The following is a description of a gene set: Human Gene Set: SCHAEFFER_SOX9_TARGETS_IN_PROSTATE_DEVELOPMENT_UP Predicted targets of SOX9 that are up-regulated during early prostate development. from publication Schaeffer EM, Marchionni L, Huang Z, Simons B, Blackman A, Yu W, Parmigiani G, Berman DM (PMID 18794802) studied in species Mus musculus Cancer cells differentiate along specific lineages that largely determine their clinical and biologic behavior. Distinct cancer phenotypes from different cells and organs likely result from unique gene expression repertoires established in the embryo and maintained after malignant transformation. We used comprehensive gene expression analysis to examine this concept in the prostate, an organ with a tractable developmental program and a high propensity for cancer. We focused on gene expression in the murine prostate rudiment at three time points during the first 48 h of exposure to androgen, which initiates proliferation and invasion of prostate epithelial buds into surrounding urogenital sinus mesenchyme. Here, we show that androgen exposure regulates genes previously implicated in prostate carcinogenesis comprising pathways for the phosphatase and tensin homolog (PTEN), fibroblast growth factor (FGF)/mitogen-activated protein kinase (MAPK), and Wnt signaling along with cellular programs regulating such 'hallmarks' of cancer as angiogenesis, apoptosis, migration and proliferation. We found statistically significant evidence for novel androgen-induced gene regulation events that establish and/or maintain prostate cell fate. These include modulation of gene expression through microRNAs, expression of specific transcription factors, and regulation of their predicted targets. By querying public gene expression databases from other tissues, we found that rather than generally characterizing androgen exposure or epithelial budding, the early prostate development program more closely resembles the program for human prostate cancer. Most importantly, early androgen-regulated genes and functional themes associated with prostate development were highly enriched in contrasts between increasingly lethal forms of prostate cancer, confirming a 'reactivation' of embryonic pathways for proliferation and invasion in prostate cancer progression. Among the genes with the most significant links to the development and cancer, we highlight coordinate induction of the transcription factor Sox9 and suppression of the proapoptotic phospholipid-binding protein Annexin A1 that link early prostate development to early prostate carcinogenesis. These results credential early prostate development as a reliable and valid model system for the investigation of genes and pathways that drive prostate cancer., and this is the list of marker genes: MBP, PNOC, MAOB, RDH10, DUSP6, TRIM2, TRMT9B (NCBI Gene Id 57604), EDN1, SLC39A8, VLDLR, FOXA1, TLE1, HMGN3, FST, HOXB9, FGF10, HOXA10, FGFR3, LHX6, FGFR2, BCL2L1